Given this list of marker genes Col27a1, Rarg, Poc1a, Tgfbr2, Sox9 (NCBI Gene Id 70015), Cst5, here is a description of the gene set: species: Mus musculus Mouse Gene Set: GOBP_GROWTH_PLATE_CARTILAGE_CHONDROCYTE_DEVELOPMENT The progression of a growth plate cartilage chondrocyte over time from after its fate commitment to the mature cell.